The following is a description of a gene set: Human Gene Set: GOBP_REGULATION_OF_POLYSACCHARIDE_BIOSYNTHETIC_PROCESS Any process that modulates the frequency, rate or extent of the chemical reactions and pathways resulting in the formation of polysaccharides. species: Homo sapiens, and this is the list of marker genes: INS, AP2A1, IGF1 (insulin like growth factor 1), IRS1, AKT1, HAS2, PPP1CA, SMPD3, PRKAG3, INSR, IRS2, PPP1R3F, GRB10, PPP1R3A, PPP1R3D, INPP5K, PPP1R3E, MIR1271, PPP1R3C, PDGFB (platelet derived growth factor subunit B), SELENOS, EGF, GSK3B, MIR15B, EPM2AIP1, PTH, PPP1R3B, AKT2, DYRK2, NFKB1, ENPP1, CLTC, IGF2, GCK, GSK3A, PASK, MIR195, PPP1R3G, TGFB1, SORBS1